Given this list of marker genes CCL3, ANXA4, CASR (NCBI Gene Id 846), ANXA3, GDE1, PINLYP, PLCH2, ARHGAP6, LIPC, CLC, PLCD1, PLA2G2F, PLA2G7, HRAS (NCBI Gene Id 338029), PLCL1, SCGB1A1, PROCA1, ARL1, CASP3, FAM83B, PLAAT2, ABHD3, PLA2G12A, PLA2G3, PLA1A, ASPG, DDHD1, SMPD1, PLA2G4F, PDGFRA, PLA2G4D, PITPNM3, PLD1, PLA2G12B, PLA2G15, ENPP7, PNLIP, CCR1, PLA2G2D, FYN, BDKRB2, SMPDL3B, PLA2G4E, CCL5, PLCB1, PDC, LYPLAL1, PLA2G5, GDPD5, SNCB, CCR5, PLAAT5, CHRM3, LIPG, SMPD3, ANXA5, PNLIPRP2, PLA2G2E, APOC1, PLCG1, PLCG2, PLA2G2C (NCBI Gene Id 8397), PLCL2, PDGFRB, ABHD6, ABHD16A, PNPLA8, PLA2G4B, PLB1, ABHD16B (NCBI Gene Id 140701), PLCD4, PLD4, SRC, PLD6, PLD2, SMPDL3A, NAPEPLD, PLAA, CCL8, PLA2R1, ENPP2, CHRM1, PLCB4, PLA2G1B, LPL, SNCA, F2RL2, PLD3, EDNRA, GM2A, CHRM5, PLA2G10, SEC23IP, PLCB3, GDPD1, PLAAT3, ABHD12, PNLIPRP3, PNPLA3, PLCH1, LIPH, ANXA2P2, PLAAT1, LGALS13, PNPLA7, ANXA2, STX4, PLA2G4A, PNPLA6, APOC2, PGAP6, PLCZ1, ABHD4, LYPLA1, DDHD2, PNPLA2, ABHD12B, ARF4, LCK, SMPD4, BTK, GPLD1, LIPI, PLBD1, PDPK1, PLCE1, ANXA8, PRDX6, OC90, PDIA3, GDPD3, NOTUM, ANXA1, SMPD2, PLAAT4, LYPLA2, PLA2G2A, ANGPTL3, PLCD3 (phospholipase C delta 3), PNPLA4, PLCB2, PLBD2, PLA2G4C, MGLL, LCAT, PLA2G6, PNLIPRP1, here is a description of the gene set: Catalysis of the hydrolysis of a glycerophospholipid. Human Gene Set: GOMF_PHOSPHOLIPASE_ACTIVITY studied in species Homo sapiens